Given this list of marker genes SLC7A11, SLC15A1, LRRC8D, NALF2, DLG1, PPP3R2, SLC9A9, SLC9A1, CACNA1G, LRRC8A, SLC8A1, AQP8, NHERF1, SLC2A3, AKT2, LRRC8B, SHOC2, SLC30A8, SLC19A1, NTSR1, SLC38A2, SCNN1B (NCBI Gene Id 6338), SLC15A4, LRRC8E, SLC1A2, CLTRN, HCN2, CACNA1I, MIR208B, FXYD2, SLC43A2 (NCBI Gene Id 124935), SLC39A5, P2RX5, MIR448, ATP1A4, RGS2, TSPO2, SLC8A2, SLC9C2, KCNK5, SLC7A8, SCNN1G, SEPTIN2 (NCBI Gene Id 4735), RGS4, ATP1A2, MIR24-1, SLC7A5, ISCU, CACNA1B, SLC27A5, SLC24A1, TRPV1, TRPV5, KCNJ11, KCNJ13, ATP12A, ATP4A, ARL6IP5, SLC38A1, KCNJ4, KCNJ9, SLC46A2, MS4A1, SLC39A10, TRPV4, MIR208A, PPP3CA, MIR26A1, ATP4B, TRPM1, KCNJ3, SLC46A1, SLC15A3, TRPM2, PCSK9, SLC12A2, SLC39A4, SLC5A3, SLC1A3, PPP3CC, SLC6A9 (solute carrier family 6 member 9), SLC28A1, CACNA1F (NCBI Gene Id 778), HCN4, SLC6A5, SLC12A6, SLC36A4, IFNG, SLC5A2, ACSL1, CD36, SLC16A2, CACNA1D, ABCC9, KCNN4, SLC39A6, SLC1A4, TRPV6, SLC38A5, CACNA1S, KCNJ2, SLC12A1, SLC7A2, SLC9C1, TRPV3, CLN8, SLC5A1, TNF, NALF1, ACSL5, TRPM4 (transient receptor potential cation channel subfamily M member 4), TRPV2 (NCBI Gene Id 51393), SLC3A2, ACE2, KCNH2, SLC6A20, SLC39A11, KCNJ10, SLC24A2, SLC15A2, CNGA3, SLC12A4, SLC7A1, SCNN1D, PPP3CB, SLC47A1, SLC39A12, KCNJ5, LCN2, STK39, SLC34A1 (solute carrier family 34 member 1), SLC9A7, ABCC8, SLC39A8, ATP2B4 (NCBI Gene Id 54594), ATP1B2, SLC9A6 (NCBI Gene Id 53362), KCNK9, SLC30A1, CACNA1H, SLC17A8, KCNJ12, SLC1A6, ATP1A1, P2RX1, SLC12A7, ITGB1, MIR200C, MIR210, CACNA1C, HCN3, CACNA2D1, AKAP5, SLC6A6, SLC30A5, SLC9A2, PRNP, SLC2A1, SLC6A14, ARL6IP1, FYN, ANK2, GRM1, GFAP, SLC12A8, SLC6A13, SLC43A1, LRRC8C, SLC8A3, CACNA1E, SLC9A4, ATP1B1, PPP3R1 (NCBI Gene Id 5534), MIR30D, ATP1A3, THBS1, SLC6A7, MIR103A1, SLC2A10, ASIC5, LRP2, CACNA1A, SLC7A3, HCN1, SLC12A3, KCNJ15, KCNJ1, SLC9A3, IRS2, KCNJ6, SLC9A5, SLC38A4, KCNJ14, NEDD4L, SLC1A5, PER2, KCNE2, SLC27A1, SLC36A1, STEAP2, SLC38A3, PSEN1, SLC22A2, SLC5A6, AKT1, SLC24A4, SLC12A5, SLC6A1, KCNQ1, SLC39A14, KCNJ18, SLC22A4, ATP1B3, KCNJ16, SCNN1A, SLC1A1, SLC2A5, KCNJ8, GRM6, here is a description of the gene set: studied in species Homo sapiens The directed movement of some substance from outside of a cell, across the plasma membrane and into the cytosol. Human Gene Set: GOBP_IMPORT_ACROSS_PLASMA_MEMBRANE